Given this list of marker genes Rab11fip3, Inpp5f, Rab8b, Stx6, Eipr1, Snx17, Snx4, Dennd1c, Gripap1, Rab7, Ankrd27, Ehd1, Snx3, Ehd3, Rab11b, Snx27, Arf6, Atp6ap1, Vps13b, Vps29, Lmtk2, Rab17, Epg5, Rab12, Scarb2, Nsg1, Grip1, Vamp4, Snf8, Micall1, Actn2, Ptpn23, Rab14, Rab8a, Fcgr2b, Arhgap1, Arhgap44, Zdhhc2, Lrrc7 (NCBI Gene Id 319537), Rab35, Entr1, Vps35, Snx30, Ankrd50 (NCBI Gene Id 99696), Snx7, Mtmr4, Vti1a, Vps39, Wipf3, Dennd1b, Rab11fip4, Bves (blood vessel epicardial substance), Vps26a (NCBI Gene Id 30930), Myo5b, Hgs, Vps52, Commd1, Cmtm6, Vps35l, Vps51, Bltp1, Rab11a, Ehd2, Micall2, Vps50, Snx12, Atp9a, Rab13, Stx16, Stx12, Ndrg4, Vps26c (VPS26 endosomal protein sorting factor C), Vps53, Pla2g3, Arhgap8, Sorl1 (sortilin-related receptor, LDLR class A repeats-containing), Dennd1a, Trarg1, Scrib, Ehd4, Ccdc93, Snx31, Washc1, Eps15, Ccdc22, Arl4c, Grip2, Pla2g4e, Akap5, Acap2 (ArfGAP with coiled-coil, ankyrin repeat and PH domains 2), Gga3, here is a description of the gene set: Mouse Gene Set: GOBP_ENDOCYTIC_RECYCLING The directed movement of membrane-bounded vesicles from endosomes back to the plasma membrane, a trafficking pathway that promotes the recycling of internalized transmembrane proteins. species: Mus musculus